The following is a description of a gene set: Defects of contact activation system (CAS) and kallikrein/kinin system (KKS) studied in species Homo sapiens Human Gene Set: REACTOME_DEFECTS_OF_CONTACT_ACTIVATION_SYSTEM_CAS_AND_KALLIKREIN_KININ_SYSTEM_KKS, and this is the list of marker genes: GGCX, F9, F8, VWF, F11, F10, SERPING1, F12, GP9, F2, GP1BA, GP1BB, GP5, TPST1, KLKB1, TPST2